Given this list of marker genes NOP56, RCL1, RAB27B, PC, IDE, EMX2, SEPTIN1, NCL, FKBP4, CPA3, NT5C3B, ODC1, NSUN2, POLR1B, HLA-DQA2, RIF1, NOP58, PDIA5, IKZF2, MFNG, RIPOR1, PPAN, NPM1, CYP11A1, F2RL3, NUTF2, HMGN1 (NCBI Gene Id 3150), DIS3, BZW2, C1QBP, SF3B3, PTPN9, FUT7, SLC7A5, MAT1A, CLEC10A, NOLC1, P2RY10, RPL23, AHCY, SMARCC1, SLC1A5, SERPINA3, TRIM28, FAM20A, NPL, CSGALNACT2, FBXW4, PAXBP1, STC2, SHMT2, GATA2, ST6GAL1, MGAT5, NT5C3A, SLC7A8, HLA-DRB1, TF, TESPA1, PARP8, PAPSS2, RUVBL2, GAS5, MBOAT2, FUT8, SPNS2, CCT6A, APEX1, MEP1B, TMEM97, NRGN, FCER1A, EIF4E (eukaryotic translation initiation factor 4E), SRSF7, PGRMC1, RCOR2, ERH, TASP1 (taspase 1), LAMA5 (laminin subunit alpha 5), AQP9, IVNS1ABP, TRBV10-2, GTPBP4, PSAT1, NRIP1, PPEF2, GART (phosphoribosylglycinamide formyltransferase, phosphoribosylglycinamide synthetase, phosphoribosylaminoimidazole synthetase), XPOT, TIMM8A, ADGRG1, IFITM3, HSPH1, GNAL, NOP16, RGS5, SNHG5, CALR, TNFSF11, F9, IKZF4, TRIM37, SINHCAF (SIN3-HDAC complex associated factor), CD48, WDR43, BIN1, KCNK5 (potassium two pore domain channel subfamily K member 5), HSPD1, TXK, TMTC2, ST7, PPP1R14B, AASDHPPT, SYTL3, SLC16A1, SLC22A3, OSBPL3, SOX4, CDK4, SPINT2, F2R, SSR3, CDH17, MSH2, NME1, ZFAS1, ANKRD10, UTP4, EPCIP, NARS1 (asparaginyl-tRNA synthetase 1), CBFA2T3, HLA-DRA, SOD1, here is a description of the gene set: Genes defining proliferation and self renewal potential of the bipotential myeloid cell line FDB. Human Gene Set: BROWN_MYELOID_CELL_DEVELOPMENT_DN studied in species Mus musculus from publication Brown AL, Wilkinson CR, Waterman SR, Kok CH, Salerno DG, Diakiw SM, Reynolds B, Scott HS, Tsykin A, Glonek GF, Goodall GJ, Solomon PJ, Gonda TJ, D'Andrea RJ (PMID 16769770) Mechanisms controlling the balance between proliferation and self-renewal versus growth suppression and differentiation during normal and leukemic myelopoiesis are not understood. We have used the bi-potent FDB1 myeloid cell line model, which is responsive to myelopoietic cytokines and activated mutants of the granulocyte macrophage-colony stimulating factor (GM-CSF) receptor, having differential signaling and leukemogenic activity. This model is suited to large-scale gene-profiling, and we have used a factorial time-course design to generate a substantial and powerful data set. Linear modeling was used to identify gene-expression changes associated with continued proliferation, differentiation, or leukemic receptor signaling. We focused on the changing transcription factor profile, defined a set of novel genes with potential to regulate myeloid growth and differentiation, and demonstrated that the FDB1 cell line model is responsive to forced expression of oncogenes identified in this study. We also identified gene-expression changes associated specifically with the leukemic GM-CSF receptor mutant, V449E. Signaling from this receptor mutant down-regulates CCAAT/enhancer-binding protein alpha (C/EBPalpha) target genes and generates changes characteristic of a specific acute myeloid leukemia signature, defined previously by gene-expression profiling and associated with C/EBPalpha mutations.